Given this list of marker genes MIR127 (microRNA 127), MIR16-1, MIR195, PRKCD, SCARB2, here is a description of the gene set: Human Gene Set: GOBP_REGULATION_OF_GLUCOSYLCERAMIDE_CATABOLIC_PROCESS studied in species Homo sapiens Any process that modulates the frequency, rate or extent of glucosylceramide catabolic process.